The following is a description of a gene set: Human Gene Set: GOBP_FATTY_ACID_DERIVATIVE_METABOLIC_PROCESS studied in species Homo sapiens The chemical reactions and pathways involving fatty acid derivative., and this is the list of marker genes: CYP4F2, ACAT1, HMGCLL1, ACSF3, ELOVL4, ACOT8 (NCBI Gene Id 10005), GGT5, GGT7, ACSL4, ABCD1, ELOVL7, ALOX15, THEM5, ACSM2A, ELOVL3, ELOVL2, PTGR1, GGTLC3, SCP2, TYRP1, ELOVL5, NUDT8, HACD1, FASN, ELOVL1, ACACA, PECR, HMGCS2, CBR4, ACSL5, ALOX12, OXCT2, EHHADH, GGT6, ALOX15B, ACSBG2, AWAT1, GGT2P, NUDT19, AWAT2, TECR, ACSS3, SLC27A2 (solute carrier family 27 member 2), ACOT7, HSD17B4, PPT1, HACD2, FAR1, FADS2, ABHD16A, CYP4F12, ACSL1, DPEP1, DGAT2, HSD17B12 (NCBI Gene Id 51144), GGTA1, HPGD, LYPLA2, CYP4F3, PAM, ACSL3, TMEM135, AACS, SLC27A5, DPEP2, ABCD2, ACSBG1, HTD2, FAR2, HMGCL, PPT2, OXCT1, ALOX5, GGTLC2, ALDH3A2 (aldehyde dehydrogenase 3 family member A2), GGTLC1, DGAT1, ELOVL6, GCDH, NUDT7, GGT3P, FITM2, GGT1, CYP4A11, ACOX1, ACSL6